The following is a description of a gene set: Genes negatively differentially expressed in cell type: NK cell upon treatment with cytokine: IL-2 in mouse lymph nodes in vivo. Mouse Gene Set: CUI_NK_CELL_IL2_RESPONSE_DN Cytokines mediate cell-cell communication in the immune system and represent important therapeutic targets. A myriad of studies have highlighted their central role in immune function, yet we lack a global view of the cellular responses of each immune cell type to each cytokine. To address this gap, the authors created the Immune Dictionary, a compendium of single-cell transcriptomic profiles of more than 17 immune cell types in response to each of 86 cytokines (>1,400 cytokine-cell type combinations) in mouse lymph nodes in vivo. A cytokine-centric view of the dictionary revealed that most cytokines induce highly cell-type-specific responses. For example, the inflammatory cytokine interleukin-1β induces distinct gene programmes in almost every cell type. A cell-type-centric view of the dictionary identified more than 66 cytokine-driven cellular polarization states across immune cell types, including previously uncharacterized states such as an interleukin-18-induced polyfunctional natural killer cell state. studied in species Mus musculus from publication Cui A, Huang T, Li S, Ma A, Pérez JL, Sander C, Keskin DB, Wu CJ, Fraenkel E, Hacohen N (PMID 38057668), and this is the list of marker genes: Klrk1, Cd28, Neurl3, Ube2b, Ctla2a, Rbm5, Btg2, H2az1, Fth1, Septin6, Ripor2, Ipcef1, Hspa1a, Agtrap, Acyp1, Prr13, Zfp36l1, Slc38a2, Mxd4, Rapgef6, Psmb9, Sp140, Pnkd, Fosb, Ppil2, S1pr4, Ahnak, Arid5b (NCBI Gene Id 71371), Cd37, Mfsd6, Pdcd4, Pnrc1, Twf2, Adcy7, Clic1, Map4k4, Ddx5, H2-Q7, Commd4, Pdgfb, Macf1, Maf1, Btg1, Hint2, Sh3bgrl, Fyb1, Shisa5, Abcg1, Irf2, Cyb5a, Arl6ip5, Ccdc82, Kif21b, Ccndbp1, Cnp, Vgll4, Ssbp3, Sirt7, Tprg1l, Ifi209, Utrn, Rbpms, Gnai2, Slc25a4, Tut4, Acaa2, Rgs2, Gbp7, Mndal, Itm2a, Ptpn18, Rsrp1 (arginine/serine rich protein 1), Samd9l, Hpcal1, Fam117a, Vps28, Scand1, Cited2, Iqgap1, Tent5a, Gpsm3, Gprin3 (NCBI Gene Id 77535), Pfdn5, Emb, Gpx4, Cirbp, Heca, Use1, Pbxip1, Klrd1, Pglyrp1, S1pr1, Map1lc3b (microtubule-associated protein 1 light chain 3 beta), Rabac1, Parp8, Mirt1, Phip, Plgrkt, Scp2, St8sia4, Atp1b1, Ppp3ca, Phf21a, Coq10b, Gimap6, Glmp, Arhgap45, Arl6ip1, Phf1, Atf7ip, Cd27, Jak1, BC005624, Ubc, H2-T23, Irf7, Arhgap15, Hmgb2, Fuca1, Tm6sf1, Antkmt, Atp6v1d, Arpc3, Ostf1, Klf6, Ifi203, Dcxr, Mier1, Slc12a6, Ssh2, Sytl2, Sorl1, Cnot6l, Uba52, Ly6e, Arhgdib, Ogt, Ppp1r15a, Add1, Pcmtd1, Tmem59, Tbc1d10c, AB124611, Cnn2 (NCBI Gene Id 12798), Wls, Acaa1a, Pycard, Maf, Grap, Zfp36l2, Ypel3, Ighm (NCBI Gene Id 432703), Klf2 (NCBI Gene Id 16598), Itgb1, Chd3, Olfm1, Sipa1, H2-Q4, Osbpl9, Ubn2, Junb, Jun, Idnk (idnK gluconokinase homolog (E. coli)), Elf1, Commd8, Prkcb, Brd9, Hcst, Crybg1, S100a10, Fam204a, Rabgap1l, H2az2, Selplg, Rp9, Ankrd12, Rtp4, 9930111J21Rik2, Arid4a, Slfn2, Ifngr1, Mpnd, Ech1, Cdc42ep3, Vezf1, Tmem50a, Pdlim1, Scamp3, Klhl24, Dnajb1, Eef1a1, Spry2 (sprouty RTK signaling antagonist 2), Zfp512, H2-K1, Sri, Jmjd1c, Npc2, Cast, Cox7a2l, Stk24, Bnip3l, Slc50a1, Dapk2, Cd96, Klhl6 (NCBI Gene Id 239743), Nlrc3, Fau, Akap13, Selenop, Dap, Entrep3, Cxcr4 (NCBI Gene Id 12767), Txnip, Otulinl, Tnfaip3, Ubb, Stat1, Fos, Ucp2, Crebrf, Cdk2ap2, Dusp1, Cd7, Add3, Tsc22d3, Celf2, Eif3f, Stard10, Fcgr3, Tmem71 (transmembrane protein 71), Il18r1, Smpdl3a, Mapk3, Lsp1, Trim12a, Ctsw (NCBI Gene Id 13041), Frmd8, Tnfsf12, H1f2, Niban1, Pigp, Yipf1, Atp11b, Crip1, Ccr2, Itm2b, Qrfp, Tsc22d4, Txk, H2-D1, Syf2, Tyrobp (TYRO protein tyrosine kinase binding protein), Arf5, Htatip2, Vamp8 (vesicle-associated membrane protein 8), Foxp1, Tcf7, Pik3r1, Ms4a6b, Aplp2, Ndufa6 (NCBI Gene Id 78837), Znrf1, Itpkb, Rgs1, Tespa1, Pttg1, Zbtb20, Itgb7, Jakmip1, St3gal6, Sat1 (NCBI Gene Id 20229), Sptbn1, Cdkn2d, Mknk2, Atxn7l1, Ltb, Dnajb4 (NCBI Gene Id 76019), Rhob (ras homolog family member B), Limd2, Camk2n1, Smad7, Epsti1, Jund, Oard1, Ccl5, Pold4, Uqcrh, Ctdsp2, Rac2, Tbc1d1, Rnf167, Gmfg, Prkacb, Tnrc6b, Tspo, Gnb2, Gabarap, Higd2a, Ier2, Ube2h (NCBI Gene Id 97337), Ddt, Kif13b, Il7r, Trappc6a, Stat4, Malt1, Arid4b, Hspa1b, Serinc3, Ppp2r5c, S100a11, Tnfaip8l2, Dhrs7 (dehydrogenase/reductase 7), Smap2, Tecpr1, Zyx, Man2b1, Ms4a4b, Saraf, Cd84, Thap3, Anxa1, Peli1, Tnik, Ier5, Cd2, Cited4, Myl12b, Evl, Ifi208, Srpk2, Tle5, Arl5c, Zfp36, Pitpnm1, Arhgef1, Svbp, Ifi206, Klrc2, Skap1, Ppp1r12a, Sh3kbp1, Ssbp2, Neat1, Cd9, Sp100, Lamtor2, Ddit3, Nsmce1, Cxcr3, Zfp945, Clk1 (NCBI Gene Id 98487), Lpxn, Uba7, Trp53inp1